Given this list of marker genes MMP20, ENSG00000271776, LINC02505, LINC02974, NEFM, LINC00348, TRHR, TMEM74, SLC17A6, P2RX3, SUSD4, CPNE9, OBI1-AS1, POU4F2, LRRTM2, CRABP1, LINC01606, OPN4 (opsin 4), ENSG00000248540, MFSD14A, CHRNA6, DDX50P2, CHRNB3, INA, TRHDE, RPL31P54 (ribosomal protein L31 pseudogene 54), RBPMS, POU4F1, TFAP2D, TRARG1, here is a description of the gene set: from publication Cao J, O'Day DR, Pliner HA, Kingsley PD, Deng M, Daza RM, Zager MA, Aldinger KA, Blecher-Gonen R, Zhang F, Spielmann M, Palis J, Doherty D, Steemers FJ, Glass IA, Trapnell C, Shendure J (PMID 33184181) The gene expression program underlying the specification of human cell types is of fundamental interest. The study authors generated human cell atlases of gene expression and chromatin accessibility in fetal tissues. For gene expression, the study authors applied three-level combinatorial indexing to >110 samples representing 15 organs, ultimately profiling ~4 million single cells. The study authors leveraged the literature and other atlases to identify and annotate hundreds of cell types and subtypes, both within and across tissues. Our analyses focused on organ-specific specializations of broadly distributed cell types (such as blood, endothelial, and epithelial), sites of fetal erythropoiesis (which notably included the adrenal gland), and integration with mouse developmental atlases (such as conserved specification of blood cells). These data represent a rich resource for the exploration of in vivo human gene expression in diverse tissues and cell types. Marker genes curated from the annotated cluster as represented in the Descartes Human Gene Expression During Development database. Human Gene Set: DESCARTES_MAIN_FETAL_GANGLION_CELLS species: Homo sapiens